Given this list of marker genes RC3H2, CD69, PNP, SLC4A2, PRDM1, NFKBID, TARM1, LILRB1, TGFBR2, IHH, ZAP70, HLX, KLHL25, GATA3, ITPKB, LGALS1, IRF4, CD83, TNFSF4, RUNX1, ZBTB7B, CD55, IL23A, XCL1 (NCBI Gene Id 92337), TBX21, TNFSF18, PTPRC, RHOA, HLA-DRB3, CBLB, SMAD7, FOXP3 (NCBI Gene Id 50943), IRF1, BCL6, MALT1, HMGB1, ZBTB16, CD28, RASAL3, CRTAM, NCKAP1L, IFNG, ANXA1, TNFRSF14, CD274, RIPK2, GLI3, ASCL2, IL12A, BRD4 (NCBI Gene Id 90616), GPR65, AP3B1, HLA-E, ZC3H12A, LGALS9C, SHH, AP3D1, SH3RF1, EP300, ADA, CLEC4G, JAK2, HSPH1, AGER, CD300A, LGALS9B, IL12B, JAK3, RUNX3, KCNK18, TWSG1, IL2RA, IL23R, NFKBIZ, PRKCQ, HLA-DRA, IL27, ADORA2A, CD81, CCL19, MAPK8IP1, CD86, IL18, IL2, HLA-A, CCR2, CARD11, DAPL1, IL2RG, PRKCZ, MIR21, SOCS5, CD3E, BATF, OPA1, NKAP, HLA-DRB1, NLRP3, ARG2, LGALS9, NDFIP1 (NCBI Gene Id 80762), CBFB, RC3H1, TYK2, LOXL3, EBI3, CD80, SASH3, IL4R, RARA, SHB, ZNF683, BRD2, SYK, LGALS3, ITCH, VSIR, LILRB4, STAT5A, JUNB, HFE, IL12RB1, SOCS1, CD160, here is a description of the gene set: species: Homo sapiens Human Gene Set: GOBP_REGULATION_OF_ALPHA_BETA_T_CELL_ACTIVATION Any process that modulates the frequency, rate or extent of alpha-beta T cell activation.